Given this list of marker genes Lrrtm1, Prickle2, Lats1, Ptk2b, Nlgn1 (neuroligin 1), Nrxn1, Fgfr1, Caskin1, Lrrc4b, Ptprs, Sipa1l1, Lrfn1, Cript, Lrfn4 (NCBI Gene Id 225875), Cbln1, Prickle1, Grid2, Il1rap, Abi3bp, Abi3 (ABI family member 3), Ptprd (NCBI Gene Id 71786), Lrrtm2, here is a description of the gene set: Mouse Gene Set: GOBP_REGULATION_OF_POSTSYNAPTIC_DENSITY_ASSEMBLY species: Mus musculus Any process that modulates the frequency, rate or extent of postsynaptic density assembly, the aggregation, arrangement and bonding together of a set of components to form a postsynaptic density.